Given this list of marker genes RTTN, DSP, JUP, GJA1, NEDD4L, here is a description of the gene set: A soft tissue continuity in the anteroposterior axis between the fourth (ring) to the fifth (little) finger that extends distally to at least the level of the proximal interphalangeal joints. studied in species Homo sapiens 4-5 finger cutaneous syndactyly Human Gene Set: HP_4_5_FINGER_CUTANEOUS_SYNDACTYLY